Given this list of marker genes TGFBR3L (transforming growth factor beta receptor 3 like), MAP3K7, FKBP1A, LEFTY2, LEFTY1, TGFBR3, TGFBRAP1, ENG, USP15, TGFBR1, TGFB1, SNX6, SMURF1, TGFBR2, SMAD6, SMAD7, SMAD3, BAMBI, TGFB3, SMAD2, TGFB2, INHBC, RASL11B, LRG1, FERMT2, AMH, here is a description of the gene set: Human Gene Set: GOMF_TRANSFORMING_GROWTH_FACTOR_BETA_RECEPTOR_BINDING species: Homo sapiens Binding to a transforming growth factor beta receptor.